The following is a description of a gene set: species: Mus musculus Reactome Pathway: Conjugation of benzoate with glycine electronically inferred by orthology from the curated human pathway This event has been computationally inferred from an event that has been demonstrated in another species.<p>The inference is based on the homology mapping from PANTHER. Briefly, reactions for which all involved PhysicalEntities (in input, output and catalyst) have a mapped orthologue/paralogue (for complexes at least 75% of components must have a mapping) are inferred to the other species. part of: Conjugation of carboxylic acids, and this is the list of marker genes: Glyatl3, Acsm1, Acsm2